The following is a description of a gene set: Genes predicted to be targets of miRBase v22 microRNA mmu_miR_6988_5p in miRDB v6.0 with MirTarget v4 prediction scores > 80 (high confidence targets). studied in species Mus musculus Mouse Gene Set: MIR_6988_5P from publication Chen Y, Wang X (PMID 31504780), and this is the list of marker genes: Rbmyf7, Zfp395, Dab2, Cnnm2, Gsg1l, Zmiz2, Srrm4, Fgf12 (fibroblast growth factor 12), Tnip1, Kdm5c, Gins2, Phf8, Anks3, Acsl4, Rbmyf1, Drp2, Gucy2f, Rbmyf2 (NCBI Gene Id 100042874), Grk6, Gm1110, Ctdp1, Hspa13, Creg1, Ebf1, Sost, Rab7, Rnf182 (NCBI Gene Id 328234), Rbmyf6, Rtkn2, Zfp503, Lats1, Klrg1 (killer cell lectin-like receptor subfamily G, member 1), Nacc2, Cyp3a13, Ube2ql1, Gnat1, Rbmyf3, Psme3, Dusp15 (dual specificity phosphatase-like 15), 1700018F24Rik, Zfp827, Sema4g, Acer1, Sema6a, Faah, Epn2, Spock1, Syn2, Pa2g4, Umps, Hlf, Tbx6, Cdkn2aipnl, Abr, Adgrl2 (adhesion G protein-coupled receptor L2), Adcy9, Rnf123, Ly6g6c, Strc, D7Ertd443e, Vdr, Tsc1 (NCBI Gene Id 64930), Iqsec2, Emp2, Arnt2, Nfatc2, Rbmyf5, Septin5, Xirp1, Fga, Cd300a, Rbmyf8, Nt5c3b, Fxr2, Nalcn, Pycr1, Sp6, Mt1, Rbmy (NCBI Gene Id 19658), Rbmyf9